The following is a description of a gene set: Immunoregulatory interactions between a Lymphoid and a non-Lymphoid cell Mouse Gene Set: REACTOME_IMMUNOREGULATORY_INTERACTIONS_BETWEEN_A_LYMPHOID_AND_A_NON_LYMPHOID_CELL studied in species Mus musculus, and this is the list of marker genes: Ighv5-17, H2-T22, Cd22, Ighv3-1, Ighv5-12-4, Cd300c, Ighv7-4, Ighv3-5, Ighv5-9-1, Siglecg (NCBI Gene Id 243958), Ighv5-12, H2-M10.6, Cd3g, Pilra, H2-M3, Ighv16-1, C3, Col2a1, Cd34, Cd200r2, Ighv3-6, Siglec1, Itgb7, Ighv3-8, Madcam1, H2-M1, Igkv1-117, Ighv12-3, Oscar, H2-M10.4, Cd8a, H2-M11, Trbv15, Vcam1, Igkv20-101-2, Ighv8-4, Igkv17-121, Col17a1, Cd40, Cxadr, H2-Q6, Igkv2-112, Igkv1-122, Cd160, Cd1d1, Igkv15-103 (NCBI Gene Id 692169), Ighv13-2, H2-Q7, Ighv5-2, Ighv8-5, Igkv1-133, H2-K1, Ighv8-8, Trac, Igkv1-88, Ighv6-5 (NCBI Gene Id 639510), Igkv1-131, Cd247, Trem1, Itgb2, H2-M9, Cd200, Icam2, Ighv6-6, Igll1, Igkv1-110 (immunoglobulin kappa variable 1-110), Itga4, Itgal, Pianp, Pvr, Ifitm2, Igkv8-21, Igkv16-104, Ighv8-2, Cd81, Sell, H2-M10.1, Ighv5-6, Cd300e, Treml2, Iglc1, Siglece, Fcgr4, Trem2, Fcgr3, Hcst, Ighv8-13, Igkv1-132, Trbv16, B2m, Sftpd, H2-Q1, H2-M10.2, Ighv3-3, Cd300c2, Jaml, Kir3dl2, Cd8b1, Ifitm7, Ighv8-12, Ifitm1, Ighv5-4, Ighv7-2, H2-T23, Slamf6, Klrk1, Ighv8-9, Iglc2, Nectin2, H2-T10, Ighv8-11, Trav16 (NCBI Gene Id 195297), Kir3dl1, H2-M10.3, H2-Q10, Tyrobp, Cd300lg, Ighv5-9, Igkv1-35, Cd33, H2-M5 (histocompatibility 2, M region locus 5), Raet1e, Ighv3-4, H2-Q4, Slamf7, H2-Q2, Cd3e, Igkv11-125, Ifitm3, Cd3d, Igkv18-36, Ighv8-6, Col1a1, Ifitm6, Lair1, Npdc1, Ighv6-4, Clec4g, Igkv1-135, Ighv6-7, Cd300a, Cd96, Col1a2 (collagen, type I, alpha 2), H2-M10.5, Fcgr2b, Trav19 (T cell receptor alpha variable 19), Ighv5-15, Icam5, Itgb1, Cd226 (NCBI Gene Id 225825), Ighv7-3, Igkv2-137, Ighv5-16, Ighv6-3, Siglecf, Igkv1-99, Cd300lb, Cd19, H2-M2, Crtam, Icam4, Col3a1, Treml1, Siglech, Treml4, Icam1, Igkv2-109, Cd40lg